The following is a description of a gene set: part of: Signaling by CTNNB1 phospho-site mutants species: Homo sapiens Reactome Pathway: CTNNB1 S45 mutants aren't phosphorylated S45 mutants of beta-catenin have been identified in colorectal and hepatocellular carcinomas, soft tissue cancer and Wilms Tumors, among others. These mutations abolish the CK1alpha phosphorylation site of beta-catenin which acts as a critical priming site for GSK3 phosphorylation of T41( and subsequently S37 and S33) thus preventing its ubiquitin-mediated degradation., and this is the list of marker genes: PPP2CB, GSK3B, CSNK1A1, PPP2R5B, PPP2R5E (protein phosphatase 2 regulatory subunit B'epsilon), AXIN1, CTNNB1, PPP2R1B, PPP2R1A, PPP2CA (protein phosphatase 2 catalytic subunit alpha, NCBI Gene Id 5515), PPP2R5D, PPP2R5C, APC, PPP2R5A, AMER1